The following is a description of a gene set: Human Gene Set: GOBP_REGULATION_OF_CELL_POPULATION_PROLIFERATION studied in species Homo sapiens Any process that modulates the frequency, rate or extent of cell proliferation., and this is the list of marker genes: ALOX5, CRTAM, MIR1-1, CTCF, IL11RA, PDGFA, RB1CC1, SMAD6, MIR195, APOE, GGNBP2, SPHK2, WNT2, CRH, C8orf17, LILRB2, MIR339, IGF1R, ATG101, RUNX2, TRAF5, RAB33B, ITGB3BP, SSTR4, ABCC8, DRD2, HTR2A, FOXJ2, PPARD, PAWR, INPP5D, CREB3, IGFBP2 (NCBI Gene Id 3485), TGFB2, TGFBR3, FOXE3, FBLN1, GATA3, KRT4, ATRAID, FLT3LG, NOTCH3, ACKR3, JAML, NAMPT, MIR129-1 (microRNA 129-1), DDRGK1, RAPGEF2, FCGR3A, GNAI2, MIR96, PTK2B, PRAMEF2, BMPR2, RBP4, JUN, CEP43, CD4, WDR48, ZNF503, PYCARD, IL18, MIR20A, TAL1, NKX2-8, MIR27A, GAS8, CLCF1, MIR182, MMP2, CGA, IFI30, BAK1, BICRAL, CUL4A, EMP2, CHP2, CDH3, TOB1, DDR2, FZD9, BIRC2, ADRA2A, ILK, TFAP2E, CLU, NUS1 (NUS1 dehydrodolichyl diphosphate synthase subunit), DUX4, MAB21L1, MIF, DNAJB2, ECM1, CCL26, IGF1 (NCBI Gene Id 3479), MIR320B2, PPARG, HLA-A, FZD5, MIR29B1, VAX1, PRKG1, CR1, TPD52L2, ISL1, SRPX, SPINT2, CSF3, ABL1, SCIN, IL9R, SLAMF1, IGFBP5, SLC6A4, VIP, STAT6, MTSS1, PEX2, CD86, TNC, CAPN1 (calpain 1), IL6, TCF3, FUT1, NME1, RUNX3, APC, PKD2 (polycystin 2, transient receptor potential cation channel), HCLS1, NDRG2, PHLDA2, CIB1, SMARCD3, NMI, MATK, MIR1290, SHANK2, ING4, CXCR2, MIR10B, IAPP, SH3RF1, VSIG4, AVPR2, NDFIP1, RASSF10, LAMC2, SAAL1, PIM2, FADD, CCR2, ZNF304, FNTB, PPP1R9B, POR, HOXA3, SELENON, CYP27B1, SLURP1, PDX1, MIR132 (NCBI Gene Id 406921), ACER3, YAP1, ATXN1L, GNL3, AIMP1, TNXB, ZBTB16, CDKN2B, MIR133B, SCN5A, KSR1, NME2, P2RY6, MIR101-1, CASC11, ACE2, CDK2, GLMN, PAXBP1, MIR149, SPEG, CBLB, MARVELD3, GREM1, TINF2, TSLP, GDF9, HAVCR2, APELA, RARB, BTG4, CFDP1, EAF2, C1orf56, IL10 (NCBI Gene Id 3586), IL12A, EDN2, PID1, IL15, PML, VSX2, BTG2, EDN1, NFIB, CTBP1, WWC2, HGS (NCBI Gene Id 9146), BTG3, CCL24, FSHB, FGF9, JUP, H2AC6, KANK2, VASH2, CCNB1, GFAP, HPGDS, EGF, TFF1, S100B, UTP20 (UTP20 small subunit processome component), MAFG, B4GALT1 (NCBI Gene Id 2683), PER2, MIR20B, ANGPT1, BCL2L1, SERTAD1, STX3, FLNA, EGR3, FGF10, TRIM71, NOX1, LAMB1, PDGFD, IL13, MIR520A, NDRG1, KLF10, EMD, FZD7, ARHGAP5, EDN3, BCL7A, RHOA (NCBI Gene Id 387), ATF3, GAB2 (NCBI Gene Id 9846), DBF4B, SSR1, PHB2, GPX1, HES1, LMO1, NRG1 (neuregulin 1), SPN, FGF19, MAPK14, HPGD, ATP8A2, CD24, MED1 (mediator complex subunit 1), OPRM1, CD109, GATA2, GPC3, DHCR24, MIR492, MIR137, INPPL1, PRDX4, PLCD3, GAS6, CHERP, SNAI2, DPP4 (NCBI Gene Id 1803), SUZ12, IL13RA2, JUNB, CCN6, ROBO1, MIR125A, LBX1, HDAC6, FOXJ1, HSF1, CCL11, SMAD4, PLG, MALAT1, TMEM131L, F3, NOX4, MYC, MYCN, TGFB1, ARHGEF2, ERBB2, NGF, ID2, SBNO1, DLG1, CD9, WNT3A (NCBI Gene Id 89780), SMYD2, MIR185, PRAMEF6, SPINT1, ATF2, MTA3, PARP10 (poly(ADP-ribose) polymerase family member 10), PRAMEF9, NELL1, TMEM115, IGFBP7, BTK, TP73, INS, ITGAV, SMAD7, ALK, TFAP2D, OVOL2, HLA-DPA1, IRS1, PLA2G2F, CNBP, KDR, SIRT6, PRAMEF25, PRKD1, NF2, ESM1 (NCBI Gene Id 11082), CRLF2, FOSL2, MIR335, PTPRN, TSPO, ELN, CD74, ING5, RTKN2, MIR892B, GSDME, CNOT6, EGR4, BTG1, FGF4, C18orf54, BID, AGBL4, NHERF1, PRMT1, MMP12, IL33, WDR62, APPL2, MIR873, NUAK1, RIPOR2, HNRNPU, MITF, BST1, HTN3, TNFRSF13B, MSTN (myostatin), EMC10, ZP3, PRDX3, FGFR3, MAD1L1, VHL, GPR15LG, CDH5, FGF1, EPPK1, FBXW7, PRAMEF15, CLEC7A, CCL23, ITGA4, CARD11, PIAS1, LTBP3, PRAMEF13, RAF1, SRF, PPM1D (protein phosphatase, Mg2+/Mn2+ dependent 1D), TAFA1, HPSE2, MIR126 (NCBI Gene Id 406913), ODAM, PDCD4, MAZ, HAS2, IL12B, PBXIP1, MIR204 (microRNA 204), KIFAP3, IFT57, MIR2355, PDPN, MIR27B, LIG4, AMBN, CTLA4, MIR199B, MARCKSL1, ATXN1, CNTF, CGREF1, SMARCD1, TNFSF8, NOS2, IFNG, PRKCA, WWC3 (WWC family member 3), NRAS, PLA2G5, CDCA7, ITCH, PRKCI, DLEC1, CCKBR, SH3BP4, ADRA1D (NCBI Gene Id 149), ACTB, SERPINF1, NCKAP1L, CHRD, REG3G, DYNAP, DPT, PRDM1, IL9, MIR140, PRAMEF20, IL2RA, PGR, NPM1, RPA3, ADORA2A, BCL11B, FOXF1, MIR223, NRP2, INHBA, IL12RB1, DUSP22, ATP5IF1, NKX2-6, PDCL3, ADGRG1, CD40LG, SHH, FGF2, TBX19, DGCR8, CCDC117, ZNF580, THBS1, RHOG, AGER (advanced glycosylation end-product specific receptor), KCNK2, PHB1, SMPD3, PPP1CC, TP53INP1, RGS5, PTGS2, PTH1R, CCNE1, HHEX, IFNK, MIR590, SCGB3A1, ZNHIT1, IL4I1, DACH1, CRIP2, FLCN, CDKN2C, PHF7, SMARCB1, ST8SIA1, PDF, SQLE, IL23R, MDM4 (MDM4 regulator of p53), CRNN, RARA, RIPK2, PLA2G4A, FOLR2, TBX20, PRKRA, NUP62 (NCBI Gene Id 51551), MIR92A1, FZR1, MNDA, CCR3, TIAM1, CLEC4G, TSHR, PRC1, NR1D1 (NCBI Gene Id 9572), TOB2, TBC1D8, CDC20, RBPJ, MIR193A, SST, MIR483, PRAMEF1, CTNNB1, APLNR, PRRX1, STK3, COL18A1, COL4A3, SPIN4 (NCBI Gene Id 139886), CCN3 (cellular communication network factor 3), AVPR1A, MAPK1, DHPS, DUSP1, CFLAR, RICTOR, RAP1GAP, TENM1, CSF2RA, WNT9A, FOXG1, ACTL6B, LDLRAP1, NKX2-3, SDC4, CXCR3, LTA, MMRN2, CCL8, CBFA2T3, MEF2C, FXYD2, MEAK7, DHRS2, OSR1, PDGFB, MEN1, MIR98, PTGFR, PRTN3, ATG13, MIR497 (NCBI Gene Id 574456), FZD3, TRAF6, GDNF, MIR424, MIR675, CX3CL1, MBD2, MIR143, CLDN1, IFITM1, FGF20, ELL3, STX4, CDX2 (NCBI Gene Id 1045), ACTL6A, CDC73, ARID2, PHF14, RXFP2, ADIPOQ (adiponectin, C1Q and collagen domain containing), MIR503, CASP3, TSPAN31, MIR23A, CDC25B, BST2, TBX3, THAP12, EXTL3, HLA-E, GHR, AIMP2, CBX8, MIR361, SIX1, IL7, IL24, EPO, DBH, TGFBR2, PTPN14, CYP7B1, RYK, DUSP10, APOD, SYF2, IL34, SSTR2, GKN2, NTRK1, IGF2, SULF2, SULF1, SPRY2, BMPR1A, SMIM22, SMARCA2 (NCBI Gene Id 95083), CCL5, AZGP1, XCL1, CUL3, FGF23, ITGB1, GAL, MIR486-1, CD320, HES5, NANOG, BMP5, ANXA1, MIR214, CGRRF1, MIR509-1, STAT3, MIR665, NTRK2, MSX2, MIR181C, HIPK1, FES, GATA6, CCL2, MUSTN1, ETV3, ITGB3, DVL2, RAD51B, TGFA, ERRFI1, SHOX2, FRS2, INSM1, RPS4X, CALR, CD1D, KMT2A, FOXP2, SGPP2, ACVRL1, CCPG1, EPB41L4B, PTN, JAK2, SF1, FGFR4, AQP1, NTRK3, CLDN3, SGK2, TMEM119, CCN4, IRF1, MED31, HTR2B, IDO1, IL4, SKP2, WARS1, SAV1, TBRG4 (transforming growth factor beta regulator 4), HBEGF, TIMP1, AVP, HTR1B, CSF3R, MYOD1, FUZ, PLXNB1, HP1BP3, BECN1, GDF5, NEURL1, E2F7, ROGDI, LIN28A, MIR200C, H2AC4, IRS2, SLC25A33, CCNA2, AXIN2, VTCN1, MEIS3, IRAK4, TBRG1, ZNF609, SEMA5A, FGF7, TNFRSF13C, KCNH1, SOX15, KLHL41, SIX5, MIR150, NLGN2, EBI3, MIR362, HMGB2, FNIP1, TAX1BP3, CLMN, MIR208A, CEBPA, LRRK2, AGTPBP1, SS18, ESRP2, ADAMTS8, SIX2, CEACAM1, TFAP2C, PLAAT4, PRAMEF26, CCND3, CRKL, CHRM1, CSF1, N4BP2L2 (NCBI Gene Id 88523), TNFSF13B, MLXIPL, PTGDR2, EGFL7, PRAME, CD33, ITGAX, IRF6, LAPTM5, FERMT2, MDM2, PROX1, PTPRC, SOX11, SLC25A27, PF4, AQP11, WNK2, ITGA1, ERBB4, FUT2, MIR221, REG3A, MECP2, ID4, MEGF10, DDX20, EZH2, IFT80, ZNF703, IL3, LMNA, RPA1 (NCBI Gene Id 6117), BMP2, FOSL1, MIR34B, PDE9A, FLT4, ZAP70, TMIGD3 (NCBI Gene Id 57413), FGF5, KITLG, MIR548C, MIR638, PHOX2B, MYOCD, INSL4, TNF, HTR1A, CD248, PURA, MEIS3P1, WNT10B, IFI35, EPHB1, PIM1, NFATC2, CORO1A, EFNB1, SMO, CDC7, PTGES, IGFBP6, NR2F2, MIR320E, TSC1, TYROBP, SHOC2, CDCA7L, NF1, SLC35F6, AHR, MIR30C2, OGN, PAX2, SMARCC1, DLG5, LDOC1, SRSF6, LEPR, PAX6, NPR1, CCAR1, RPS15A, ZNF777, MIR145, NCK1, TBX5, WDR77, IFT52, AGGF1, CADM4, PRAMEF5, ATAD5, SCX, ZMIZ1, CDKN2A, KAT7, MIR21, MAPK8IP1, SASH3, CTNNBIP1, SH2B3 (SH2B adaptor protein 3), RERG, TMIGD1, RPS6, FN1, AIF1, NFKBIA, MYO16, TMIGD2, MAP3K7 (NCBI Gene Id 6885), FBXO2, SDCBP, MIR487B, TIRAP, CD3E, EMILIN2, LGALS9, LRRC32, ADORA1, MAP2K5, CELA1, TEK, HEY2, HSPG2, GTPBP4, CTNNA1, DCT, TMEM250, MIR29A, FABP6, CDON, PNP (purine nucleoside phosphorylase), BTC, HSPA1A, ASCL2, TRPM4, EGR1, EIF2AK1, SERPINB3, GPAM, PPP2R5C, LIMS2, TNFSF18, SP1, JCAD, IL31RA, UHRF1, CASK, FEZF2, GPER1, IL26, CERS2, STAT5B, BRD9, SERPINF2, CLEC11A, ZNF268, ZMPSTE24, SAT1, NANOGP8, IL6ST, CNOT8 (CCR4-NOT transcription complex subunit 8), INTU, NOS3, PTBP2, RELA, C5AR1, MIR15A, FOXP3, FAM98A, ZFPM2, RREB1, APOH, NOG, DHX9, GKN3P, SKOR2, IDH2 (isocitrate dehydrogenase (NADP(+)) 2), SFRP2, PRLR, GUCY2C, MTBP, PIK3R1, FANCA, SCRIB, ING1, CDK1, CDK6, HCK, DLL4, ZBTB49, KCTD11, PTK2, MIR19B1, TOPORS, GHRL, BNC1 (NCBI Gene Id 646), BMPR1B, HDAC2, MIR329-1, SHCBP1, VEGFD, PIK3CD, DNAJA3, ACVR1C, REG1B, LBH, CX3CR1, CCDC88B, PTPN1, SPTA1, AVPR1B, LGR5, EPHB2, GLCE, NACA, SLC25A5, MSX1, EPHA4, SIRT1, NRP1, HLA-DMB, EAPP, ZBTB7C, PTPRJ, GLP2R, ZFP36L1, ARG1, CD55, CNN1, ARNT2, ENPP7, GAREM1, PRAMEF12, ATF5, LRP2, RNASEH2B, PDS5B, RPL13A, MIR711, IER5, CALCRL, GRK5, CEACAM6, TRPC5 (NCBI Gene Id 7224), SKAP2, MIR9-1, FA2H, GDF11, TBX1, KAT2B, FLT3, POU3F3, TCF7L2, ABI1, CDK4, CNOT6L, PGF, MORC3, CHST11 (carbohydrate sulfotransferase 11), FOXO4 (NCBI Gene Id 4303), BMP10, INCA1, CCND2, PDCD6, DEAF1, FERMT1, DLL1 (delta like canonical Notch ligand 1), FGF17, SPDYA, KDM4C, RAB25, MAB21L2, FGF18 (NCBI Gene Id 8817), ZP4, PDPK1, AGT (NCBI Gene Id 183), MIR1298, JAG1, PINX1, CD46, GML, RPL23, CD28, SLC4A2, HPSE, PTGIR, NTN1, CLDN19, IL3RA, PTPRZ1, SSBP3, GCNT2, CDC42, RARG, IL11, PAK1, HIPK2, TXNIP, STAT4, FUT3, E2F4 (E2F transcription factor 4), PPP3CA, TPD52, AMELX, TTK, CAV2, MN1, UMOD, SMAD1, IFIT3, EGFR, GPBAR1, SIRT2, SOX4, PRKCQ, KLB, AKT1, FCRL3, ECRG4, TNFRSF11A, MIR17HG, MMP9, CCN1, MIR133A1, PTCH1, E2F1, KMT2D, BMI1, RC3H1, WDR6, WDR13, MDK, CER1, MIR141, SERPINE2, GHRH, CD300A, PTPRM, TPM1, CRP, VSTM2A, KIT, TSPAN32, LHX2, RNF126, TNFRSF4 (TNF receptor superfamily member 4, NCBI Gene Id 7293), PYGO2, FKTN, NPY, JUND, ST18, TCIRG1, IL2, OTP, PITX2, MEIS2, FLT1, MIR146A (NCBI Gene Id 406938), OVOL1, MYDGF, NRARP, RNF41, PRKAA1, CSNK2A3, LRG1, KLF11, THPO, FAP, DELEC1, CTC1, IL5RA, SFTPD, CD200, CXCL12, NOTCH2, UFL1, POLD4, P3H3 (NCBI Gene Id 10536), DLG3, RNF10, MAPK3 (NCBI Gene Id 5595), IFNL1, FGF16, IL1A, MIR320D2, PRKDC, B4GALT7, MIR4632, TLR4, MIR134, DICER1, TCFL5, MZB1, SLC7A1 (solute carrier family 7 member 1), RBPMS2, MYB, IRAK1, ALOX15B, PELI1, TOX, BRCA2, MMP7, CDKN1B, PRAMEF33, LST1, TYK2, IHH, HIF1A, ADAMTS1, NUPR2, RBM38, ASPH, MIR410, ADAM10, PLA2G1B, NCK2, HMGB1, S1PR1, AKR1C2, ACE, CLC, MIR320D1, PLA2G2A, ZBTB17, HRAS, ASCL1, MEIS1, FGFBP1, ETS1, AKR1C3, EREG, XRCC6, ENPP3, S1PR2, HHLA2, ADA, S100A6, BRAF, OSMR (NCBI Gene Id 9180), NR4A3, CNOT7, TNFRSF14, BCAR3, CDC6 (NCBI Gene Id 990), NTF3, MYD88, GRN, JAG2, EPCAM, WWTR1, ULK1, GKN1, TFRC, NODAL, IL21, FGFR2, COPS8, PLAU (NCBI Gene Id 95176), MIR26A1, TRIM24, FMC1, PTGS1, PLPP1, ADAM17, EPOR, BLOC1S2, HNF4A, CAV1, CAV3, ZEB1, MIR10A, BCL6, EMX1, TES, CYBA, BCL6B, TRIM32, RASAL3, BCL7C, PKHD1, ZFP36, MED25, HAND2, OSR2, FABP3, LRP5, LZTS2, DNMT1, PLA2G2D, RNF139, NES, CXCL11, CSF1R, CD70 (NCBI Gene Id 970), VAV3, HLA-DPB1, LIFR, RBFOX2, CYP1B1, NDRG4, NCCRP1, XRCC5, TREM2, SLIT3, KDM2B, APOBEC1, STAMBP, TRNP1, SOX18, ZNF16, CDKN3, VEGFB, EEF1E1, TFAP2B, KRAS, PDGFRA, TSC22D1, SCGB1A1, DERL2, RIPPLY3, HLX, GHRHR, CHD5, IFNLR1, MIR29C (NCBI Gene Id 407026), PRAMEF8, PRAMEF11 (NCBI Gene Id 440560), CDK10, NGFR, LGMN, NR2E3, EID2, SSTR3, NR2E1, NKX2-5, IL23A, CXCL10, IKZF3 (NCBI Gene Id 22806), AREG, CTBP2, BIRC5 (NCBI Gene Id 332), LGALS9C, CSF2, RPTOR, STAT5A (NCBI Gene Id 6776), GJA1, HOXC10, EPS15, PRL, NPPC, PTPRU, NIBAN2, TGFB1I1, IER3IP1, TP63, MEF2D, PODN, SLC39A9, PRAMEF22, SINHCAF, RUNX1, CHRNA10, RPS9, AR, CEND1, PTPN22, CCL19, SIX3, ADGRB1, NPY5R, CAMP, FAM98B, ESR1, TNFRSF1B, PDCD2, PRAMEF19, MAGI2, PTGDS, MIR448, CACNB4, CLDN5, MIR16-1, CDH13, CD209, ASH2L, EYA1, RTN4, SLC7A11, BTN2A2, SMARCA4, ENG, WNT11, GLI1, BAMBI, FOXO3, MIR218-1, BIRC7, ADARB1, IL12RB2, STK4, RHBDD1, TNFSF9, NEAT1, CLECL1P, MIR34A, FABP7, PTPN2, BEX4, FOXP1, ITGB1BP1, SFRP5, BAX, PHIP, MIR449A, JARID2, NACC2, FGF8, WNT1, PROK1, SOX8, CRIPTO, ERN1, NAP1L1, SSTR5, TMEM127, LEP, CD38, MIR30E, BMP7, GID8, MVD, MIR320C2, GDF2, TBX2, MIR494, POU3F2, NACC1, PTHLH, C8orf44-SGK3, MIR138-1, RBM5 (RNA binding motif protein 5), RPRD1B (regulation of nuclear pre-mRNA domain containing 1B), IL7R, SFN, MIR657 (NCBI Gene Id 724027), HOXD13, ICOSLG, MIR125B1, GATA1, ARG2, THBS4, TP53I11, KLF5, HRG, HPN, LTF, TERT, HSPA1B, ATOH8, B2M, GNRH1, PIK3CA, TSC2, WWC1, SYNJ2BP, CSNK2A1, GRPR, CRLF1, MIR320B1, SGK3, WNT5A, FGFRL1, HMGN1, TLR9, MIR93, LTK, TP53, FBLN5, CNN2, JTB, ATP5F1A, GABBR1, COX17, CHRNB2, IL27, KDM1A, SGK1, VCAM1, APP, MIR15B, KRT6A, MIR205, LAMA5, ADM, FGF21, MIR222, TWSG1, BIRC6, AKIRIN1, MIR181A2, CCL14, SOD2, MFN2, ARNT, MIR519D (NCBI Gene Id 574480), NMB, SOS2, SFRP1, MAPK11, ANHX, HMGA1, BTNL2, CD80, TNFAIP3, VEGFC, TACR1, MYOG, TGFB3, LGALS9B, ARX (NCBI Gene Id 619216), STAT1, CD81, SERPINB5, SSTR1, CSNK2B, MIR342, ITGA2, PRAMEF27, VASH1 (NCBI Gene Id 22846), KLF9, ODC1, FEZF1, PRKAR1A, PRAMEF14, VSIR, FASLG, F2, KIF20B (kinesin family member 20B), MIRLET7B, CD274, PTEN, NKX3-1, CDH2, ALDH1A2, STK11, MPL, MIR30B, HMOX1, TNFSF12, SIX4, S1PR3, MIR152, FER, TNMD, TFDP1, USP17L2, BMP6, DMRTA2, TRIB1, LIF, ACER2, RBM10, LHX5, CD40, ANG, ADORA3 (adenosine A3 receptor), SULT2B1, TENT5B, CHRNA7 (NCBI Gene Id 1139), CD47, TSG101, BRICD5, TNFRSF9, EFEMP2, KLF4, CXCL5, CSK, LACRT, CREB1, KDF1 (keratinocyte differentiation factor 1), RGCC, E2F3, DAB2, EMILIN1, DISP3, TNFSF4, MNAT1, ERBB3, DAB2IP, MIR199A1, PDCD1LG2, WNT7A, NOP2 (NOP2 nucleolar protein), PRAMEF7, KLF13, LILRB1, IL1B, LIMS1, C1QL4, GHSR, INHA, TIMELESS, DLC1, NUPR1, AGO3, CXCL1, PTH, MIR24-1, KIF14, CTF1, PRAMEF17, PPP1R16B, NLRC3, SHMT2, MIR200B, TFAP2A, PTPN6, PRAMEF18, SLC39A10, PLAC8, OSM, PDE1A, WT1, PTGER2, IL20RB, A4GNT, RPS3, MIR181B1, LYN, F2R (NCBI Gene Id 2149), CITED1 (NCBI Gene Id 4435), TSPYL5, MIR320A, CEBPB, BAD, SYK, RAC2, AKT3, SAPCD2, TIPIN, TNFSF13, PBX1, PTPRK, TNFRSF8, IGFBP3, MIR301A, TRAPPC14, SIRPG, GPLD1, INSR, VEGFA, SETD4, PDGFRB, CASR, PAX7, FRZB, GNA12, PLAG1, S100A11, SLC16A2, CDKN2D, MINAR1, EFNB2, IQGAP3, CNMD, SELENOK, NPR3, TMEM196, PDCD10, MIR515-1 (microRNA 515-1), BMP4, AMBRA1, VIPR1, HMX2, HOXA5, DIS3L2 (NCBI Gene Id 282696), CNTFR, TJP1, BNIPL (BCL2 interacting protein like), CEP131, TIE1, FGF22, SCG2, GLI3, CXCL8, CDKN1A, MAPK15 (NCBI Gene Id 225689), BCHE, MARCHF7, TIAL1, ADRA1A, MKS1, MIR499A, MAP3K5, LEF1, FOXO1, BICRA, MIR22, SMAD3, SOX17, TGIF1, PLXNB3, CCND1, IL6R, TNFRSF21, CHEK1, SHC4 (NCBI Gene Id 399694), BTLA, FTO, MIR495, PITX3, TPBG, HILPDA, HLA-DRB1, PMP22, MELTF, BAP1, TICAM1, CACUL1, PTPN11, RASSF5, MIR135B, TGM1, PRAMEF10, FTH1, CD37, PLCG1, STXBP4, STAT2, PRKD2, BOK, RPS6KA2, DLX6, GPNMB, LILRB4, STRN, COPS9, DNAJA2, TAF6, P3H1, FANCL, GJB6, CCL3L3, IFT74, MIR17, TNS2, CD22, IL5, MCC, CD6, DISC1, RARRES1, ASPM, LGALS3, FGFR1, MIR34C, POU1F1, RB1, CDKN1C, CTHRC1, P3H2, MIR372, PPARGC1A, PRKCH, EDNRB, HMGA2, HDAC4, NOTCH1, APLN, OCSTAMP, SRPK2, ATM, SCAND3, MAGED1, ELANE, KCNA5, MAP2K1, CARM1, GPR37L1, DSC1, DLX5, EIF2AK2, FBXO4, SFRP4, FBXO5, SPRY1, REG1A, PRNP, NMBR, COMP, KRIT1, MST1R, HMGN5 (high mobility group nucleosome binding domain 5), BRK1, TFAP4, SOS1, RNF187, CELF1, BCL2, KDM5B, TAFA5, NOD2 (nucleotide binding oligomerization domain containing 2), PBRM1, SLC7A5, FOXM1, NUDT6, FGF3, XBP1, SERPINB7, SHC1, NR5A2, EPGN (epithelial mitogen), ETV5, VGLL4 (vestigial like family member 4), SKI, GPR183, FCGR2B, TACSTD2, CD276, CXCL9, PDGFC, MIR520H, SPARC (NCBI Gene Id 6678), RIPK3, DDR1, H2AC8, ZNF335, GSTP1, IFT172, HLA-G, VDR, NR4A1, ZBTB7B, PRAMEF4 (NCBI Gene Id 400735), HDAC1, MIR320C1, MIR130A, SOX9, PKN1, DDAH1, LAMC1, CSF2RB, TESC, RBBP4, TAC1 (tachykinin precursor 1), FGF6, BCL7B, CAPNS1, CCDC88A, AGTR1, SOX10, MIR378A, SPHK1, TGFBR1